Given this list of marker genes Hand1, Nog, Pou4f1, Prox1, Ccm2l, Zfpm2 (NCBI Gene Id 320725), Hey2, Tnnc1, Dll4, Tgfbr1, Foxh1, Mybpc3, Rbpj, Fkbp1a, Tgfbr3, Ryr2, Chd7, Nkx2-5 (NCBI Gene Id 18091, NK2 homeobox 5), Ctnnb1, Tnni1, Tnnt2, Smad7, Foxc1, Tgfb2, Tnni3, Ly6e, Epor, Myh6, Bmpr1a, Notch1, Ednra, Heg1, Ptcd2, Isl1, Dsp, Klk1b1, Med1, Naglu, Myh7, Myl2, Pkp2, Fgfr2, Bmp10, Myl3, Ube4b, Smad4, Foxc2, Epo (NCBI Gene Id 13856), Col11a1, Lrp2, Tpm1, Tgfb1, Nrg1, Hey1, Rxra (NCBI Gene Id 78740), Eng, here is a description of the gene set: studied in species Mus musculus The process in which the anatomical structures of cardiac ventricle muscle is generated and organized. Mouse Gene Set: GOBP_VENTRICULAR_CARDIAC_MUSCLE_TISSUE_MORPHOGENESIS